Given this list of marker genes DNMT3A, SAMD9L, MRAS, SETBP1 (NCBI Gene Id 284262), SOS2, SRSF2, TERT, ASXL1, SPRED2, F13B, RRAS2, GATA2 (GATA binding protein 2), ARHGAP26, LZTR1, NRAS, CBL, TET2, RAF1, TERC, KRAS, RRAS (RAS related), NF1 (NCBI Gene Id 646021), F13A1, SOS1, MAP2K1, PTPN11, IDH1, BRAF, RIT1, RASA2, KIT, here is a description of the gene set: Human Gene Set: HP_MYELOID_LEUKEMIA studied in species Homo sapiens Myeloid leukemia A leukemia that originates from a myeloid cell, that is the blood forming cells of the bone marrow.